Given this list of marker genes Hip1r, F7, Src, F3, Npr2, Hip1, Nrp1, here is a description of the gene set: Mouse Gene Set: GOBP_POSITIVE_REGULATION_OF_PLATELET_DERIVED_GROWTH_FACTOR_RECEPTOR_SIGNALING_PATHWAY species: Mus musculus Any process that increases the frequency, rate or extent of the platelet-derived growth factor receptor signaling pathway.